The following is a description of a gene set: from publication Bruins W, Bruning O, Jonker MJ, Zwart E, van der Hoeven TV, Pennings JL, Rauwerda H, de Vries A, Breit TM (PMID 18195040) studied in species Mus musculus Phosphorylation is important in p53-mediated DNA damage responses. After UV irradiation, p53 is phosphorylated specifically at murine residue Ser389. Phosphorylation mutant p53.S389A cells and mice show reduced apoptosis and compromised tumor suppression after UV irradiation. We investigated the underlying cellular processes by time-series analysis of UV-induced gene expression responses in wild-type, p53.S389A, and p53(-/-) mouse embryonic fibroblasts. The absence of p53.S389 phosphorylation already causes small endogenous gene expression changes for 2,253, mostly p53-dependent, genes. These genes showed basal gene expression levels intermediate to the wild type and p53(-/-), possibly to readjust the p53 network. Overall, the p53.S389A mutation lifts p53-dependent gene repression to a level similar to that of p53(-/-) but has lesser effect on p53-dependently induced genes. In the wild type, the response of genes to UV irradiation was strictly biphasic. The early stress response, from 0 to 3 h, results in the activation of processes to prevent the accumulation of DNA damage in cells, whereas the late response, from 12 to 24 h, relates more to reentering the cell cycle. Although the p53.S389A UV gene response was only subtly changed, many cellular processes were significantly affected. The early response was affected the most, and many cellular processes were phase-specifically lost, gained, or altered, e.g., induction of apoptosis, cell division, and DNA repair, respectively. Altogether, p53.S389 phosphorylation seems essential for many p53 target genes and p53-dependent processes. Category C genes: p53-independent genes whose expression in the absence of S389 phosphorylation is dissimilar to loss of TP53 in MEF (embryonic fibroblast) cells in response to UV-C irradiation. Mouse Gene Set: BRUINS_UVC_RESPONSE_VIA_TP53_GROUP_C, and this is the list of marker genes: Sncb, 1700017G19Rik, Agrn, Bmper, Hectd3, Efs (NCBI Gene Id 13644), Coch, Emb, Zfp955b, Ptgs1, 5330406M23Rik (NCBI Gene Id 76671), Mtor, Hpca (hippocalcin), Tlr5, Sdc4, Bves, Cxcl5, Bzw1, Sgsm1, Uba1, Polq, Pdzk1, Cdh8, Des, Zfp788, Ip6k2, Dhrs2, Krtap14, Hmgn3, 4930438A08Rik, Slc22a3, 2310030G06Rik, Krt78, Bmpr1b, Pacsin3, Etf1, Smim20, 4930407G08Rik, ENSMUSG00000128555, Kcnk16, Hsd3b3, Bcl2l15, Mep1b (NCBI Gene Id 17288), Atp6v0c, Usp14, Srrm4 (serine/arginine repetitive matrix 4), Ssbp2, Mx1, Prss41, Dhx40, Gch1, Eri1, Lyz1, Shkbp1, Psd3, Leng9, Ccnk, Lcn10, Nmu, Malat1, 1700024J04Rik, Tex35, Hsph1, Uvrag, Obi1, Gng5, Snai3, Mecom, Sh3gl2, Fgf7, Adgrv1, Axdnd1, Taok3, Pde3a, Pramel3a, Lyz2, Kcnq4, Fam210b, Rabgap1l, Kcnh2, P2ry14, Mtch2, Sik3, Eif3d, Zfp715, Entpd6, Eif3g, Klf10 (Kruppel-like transcription factor 10), Socs3, Tmc5, Dhx33, Il1rl1, Erg, Tlnrd1, Or14j4, 1700030M09Rik, 1700008K24Rik, Slc16a13, Sec14l3, Naga, Trpm2, Eif2s3x-ps1, Foxq1, Gem, Lrrc3, Klhl8